Given this list of marker genes MLN, KCTD20, SH2B1, PVT1, ECE2, MT4, AFF2, ENTREP1, IRF2BP1, SSTR5, SLC30A3, PAX8, ZKSCAN3, DPT, SPEF1, ARSL, JAK3, SLC30A1, MPP2, BCL2, MC2R, CD8B, ITPR2, PAX9, MMP25, MSX1, NEURL1, HNRNPL, F7, HOXD4, PML, PIGR, SLC6A9, HAUS5, ZNF500, PCBP3, LSM12, SLC16A5, ADAM15, KIFC3, CNTN2, KRT33A, ARC, PRELID3A, AMFR, GRIK5, IKBKE, DOK1, MOK, TBC1D22A, JRK, ATP6V0A2, TM4SF5, ZNF592, WDR62, NFRKB, ITIH4, IRF2, SLC2A1, CMA1, SLC12A4, PAIP2B, SLC22A24, FDXR, RBBP8, SLC13A2, TNFRSF25, RANBP2, CYP11A1, LBP (lipopolysaccharide binding protein), SLC6A7, SEZ6L, SLC24A1, AQP5, EXTL3, LTK (NCBI Gene Id 4058), PIGB, TLN2, KLHL18, MYO9B, BAHD1, CRCP, PIK3CB, IGSF9B, ACKR2, TMEM11, AGPS, SLC4A3, CCKAR, CAMK2G, HTR4, TMEM94, CDK13, RASSF1, GRIP2, HTR7, here is a description of the gene set: Neighborhood of JAK3 species: Homo sapiens Human Gene Set: MORF_JAK3 Neighborhood of JAK3 Janus kinase 3 (a protein tyrosine kinase, leukocyte) in the MORF expression compendium